The following is a description of a gene set: The process in which a relatively unspecialized monocyte acquires the specialized features of an osteoclast. An osteoclast is a specialized phagocytic cell associated with the absorption and removal of the mineralized matrix of bone tissue. Mouse Gene Set: GOBP_OSTEOCLAST_DIFFERENTIATION studied in species Mus musculus, and this is the list of marker genes: Apc, Ppp3ca, Gpr137b, Nedd9, Ltf, Clec2i (C-type lectin domain family 2, member i), Lrrc17, Pik3r1, Ninj1, Pias3, Il12b, Epha2, Tyrobp, Tnfaip6, Enpp1 (ectonucleotide pyrophosphatase/phosphodiesterase 1), Fgfr3, Car2, Ccr1l1, Pira12, Mtor, Fos, Sfrp1, Il23a, Inpp4b, Farp2, Asxl2, Foxp1, Ifnb1, Eeig1 (estrogen-induced osteoclastogenesis regulator 1), Dlk1, Slc4a2, Cd81, Klf10, Pou4f1, Ifng, Lrrk1, Ppargc1b, Ocstamp, Snx10, Mapk14, Clec2d, Efna2, Ceacam1, Gpr68, Lilrb4b, Gpr55, Adam8 (a disintegrin and metallopeptidase domain 8), Tnfsf11, Ift80 (NCBI Gene Id 68259), Tnf, Ctnnb1, Il4, Ccl5, Zbtb7a, Itgb3, Tnfrsf11b, Tmem64, Csf1r, Ubash3b, Siglec15, Oscar, Clec2g, Tnfrsf11a, Il17a, Pou4f2, Fbn1, Ccr1, Bbln, Gpr137 (G protein-coupled receptor 137), Slc9b2, Tcta, Nfatc1, Fshb, Fosl2, Pira1, Pilrb1, Tob2, Cd300lf, Gpr183, Prxl2a, Csf1, Atp6ap1 (NCBI Gene Id 54411), Iapp, Rptor, Notch2, Creb1, Fshr, Nf1, Sbno2, Cartpt, Nfix, Esrra, Junb, Tmem178, Gpc3, Gnas, Tjp2, Mafb, Ccn4, Ostm1, Inpp5d, Trf, Src, Cldn18, Traf6, Mitf, Lilrb4a (NCBI Gene Id 14728), Erfe, Gab2, Dcstamp, Rassf2, Calcr, Fbxw7, Glo1, Ccl9, Tgfb1, Ireb2, Bmp2, Ccl3, Fstl3 (follistatin-like 3), Gsk3b, Sh3pxd2a, Tfe3, Chuk, Anxa2, Tfrc, Tcirg1, Fam20c, Fcer1g, Cd109 (CD109 antigen), Cebpb (CCAAT/enhancer binding protein beta), Trem2, Igsf23, Pafah1b1, Il20